The following is a description of a gene set: Any apoptotic process in an inflammatory cell, any cell participating in the inflammatory response to a foreign substance e.g. neutrophil, macrophage. studied in species Homo sapiens Human Gene Set: GOBP_INFLAMMATORY_CELL_APOPTOTIC_PROCESS, and this is the list of marker genes: IRF7, NOD2, SELENOS, MEF2C, ZMPSTE24, PIK3CB, CTSL, PLEKHO2, ITPKB, IRF3, FCAR, PIK3CD, GHSR, SIRT1, ANXA1, HCAR2, MIRLET7B, SLC7A11, IL6, FASLG, CCR5, CDKN2A, CCL5